The following is a description of a gene set: studied in species Mus musculus Any process that results in a change in state or activity of a cell or an organism (in terms of movement, secretion, enzyme production, gene expression, etc.) as a result of a UV-A radiation stimulus. UV-A radiation (UV-A light) spans the wavelengths 315 to 400 nm. Mouse Gene Set: GOBP_RESPONSE_TO_UV_A, and this is the list of marker genes: Opn1sw, Mmp9, Mme, Mmp1b, Cers1, Opn5, Cryaa, Ppid, Mmp2, Timp1, Opn3, Ccnd1, Akt1, Mmp1a, Mmp3, Egfr